The following is a description of a gene set: The chemical reactions and pathways involving glycoproteins, a protein that contains covalently bound glycose (i.e. monosaccharide) residues; the glycose occurs most commonly as oligosaccharide or fairly small polysaccharide but occasionally as monosaccharide. studied in species Mus musculus Mouse Gene Set: GOBP_GLYCOPROTEIN_METABOLIC_PROCESS, and this is the list of marker genes: B3galnt2, St6galnac5 (NCBI Gene Id 99744), Chpf2, Golph3, St3gal2, Pofut2, Frey1, St3gal6, St6galnac6, Fut1, 6430550D23Rik, Mmp12, St3gal3, Porcn, Galnt9, B3gnt7, Man2a2, Dse, Ednra, Alg14, Galns, Sulf1, Ctsl, Chsy3, Galnt5, Galnt4, Vangl2, Cwh43, Large2, Il15, Cst3, Itm2a, Chst14, Mgat5, Rpn2, Gpc1, Aga, Chst11, Ctnnb1 (catenin beta 1), B4galt1, Ube2j1, Fbxo2, Itm2c, Aatf, Hs3st1, Abca7, Pgm3, Atp7a, Dhdds (NCBI Gene Id 97199), Galnt15, Lep, Pomt1, B3gnt4, Gcnt2, Psen1, Glb1, Eogt, Ust (NCBI Gene Id 338362), Pomk, St6galnac2, Rpn1, B3galt6, Fbxo27, Ccr7, St6galnac1, Chsy1, Bmp2, Prkcsh (NCBI Gene Id 19089), Tmem258, Serpina1a, Gorasp1, Dpagt1, Man2a1, Poglut3, C1galt1c1, Galnt11, Fbxo6, Xxylt1, Pomgnt2, Ago2, Glce, Fut2, Alg8, Dpm2 (dolichyl-phosphate mannosyltransferase subunit 2, regulatory), Galntl6, Edem3, Mgat4b, Bmpr1b, Hpse, Hs2st1, Abo, St3gal4, B3galt4, Hs6st1 (heparan sulfate 6-O-sulfotransferase 1), Tmem106a, Hs3st2, Adamts12, Gcnt3, Alg5, Hbegf, B3gnt5, Chp1, Adamts7, Ids, Fam20b, Slc35b2, Mgat4f, Alg6, Man1a2, Neu2, Acot8, Man1b1, Mgat4e, Chst12 (NCBI Gene Id 59031), Plcb1 (NCBI Gene Id 98861), B3galt5 (UDP-Gal:betaGlcNAc beta 1,3-galactosyltransferase, polypeptide 5), Tmtc2, Slc35d1, Jak3, Pomgnt1, Gfpt1, B3gnt8, C1galt1, Bpnt2, Gcnt1, 4930568D16Rik, Slc35c2 (solute carrier family 35, member C2), Cant1, Trex1, Ep300, B4galt2, Plod3, B3gat1, Gcnt4, Fkrp, Galnt14, Tmem260, Engase, Extl1, Gns, B4galt3, B3glct, Alg11, Galnt7, Dpm1, Galnt16, Arsb, Poglut1, Pofut1, Extl3, Naglu, Uggt1, Galntl5, Edn1, Gal3st2c, Krtcap2, B3galt9, Edem2, St8sia4, Ganab (NCBI Gene Id 14376), Tmtc4, Galnt3 (polypeptide N-acetylgalactosaminyltransferase 3), Serpina1b, Dolk, Ndst4, Angpt1, Rxylt1, Ext1, B4galt4, Pcsk6, B3gnt6, Large1, St6gal2, B4galt5, Hs3st4, Tmtc3, Cela1, Fbxo17, Alg10b, Necab1, Slc2a10, Galnt17, Trip11, Ncstn, A4gnt, Fut8, Gnptab, Mgat4d, Insr, Fut11, B3galt1, Idua, Bace2 (beta-site APP-cleaving enzyme 2), Mogs, Tet3, Bmpr2, B4gat1 (NCBI Gene Id 72430), Pmm1, Sec1, Hexb, B3galt2, Dad1, Galnt10, Dpy19l3, Ccl19, Hs6st3, Hif1a, Asgr2, Dolpp1, B3galnt1, Tmem165, Alg2 (ALG2 alpha-1,3/1,6-mannosyltransferase), Ednrb, Soat1, Galnt13, Abca2, Ramp1, Gusb, Tmtc1, Gxylt1 (NCBI Gene Id 382997), Mgat1, Nagpa, Galnt12, Srd5a3, Cog7, Hs3st5, Xylt2, Xylt1, Poglut2 (protein O-glucosyltransferase 2), Foxl1, Chst10, Ostc, Bcl2, Mgat3, Gal3st4, Entpd5, Gcnt7, Apcs, Dpy19l1, Phlda1, Stt3b, Csgalnact2, Nus1, Nccrp1, Neu4, Fktn, Ndst2, Slc35d2, Galnt6, Tnip1, Ccdc134, Fut4, St3gal1, Necab3, Cytl1, Pxylp1, Ptx3, Slc4a10, Slc10a7, Lmf1, Tusc3, Galnt2 (NCBI Gene Id 14424), Tet1, Tmem59, Chst8, Gmppa, Csgalnact1, Tcf7l2, Oga, St6gal1, St8sia3, Stt3a, Fut10, Man1c1, Chst9, Tm9sf2, Pate6, Man1a, Gbgt1, Hyal1, Il33, Hgsnat, Hs3st3a1, Slc51b, B4galnt4, Btk, Igf1, Cog3, B4galnt3, Alg12, Magt1, Crppa, St8sia2, Mgat4c, Fut7, Ces2a, Ppard, Galnt18, Ggta1, Tet2, Gata1, B3gat3, Mgat4a, St6galnac4, Pawr, Col2a1, Ndst1, Lipc, Acer2, B4galt7, Slc39a8, B3gat2, Golga2, Hs6st2, Acan, St6galnac3, Npc1 (NCBI Gene Id 98121), Edem1, Chst3, Erp44, Ext2, Gfpt2, Ccl21a, Ganc, Chpf, St8sia5, Fut9, Fbxo44, B4galnt2, B3gnt2, Manba, Necab2, Pmm2, Uggt2, Ngly1, Mustn1, Mfsd8, Park7, Ddost, Itm2b, Mlec, Alg13, Derl3, St8sia1, B3gnt3, Rab1a, Mgat5b, Mgat2 (NCBI Gene Id 217665), B4galt6, Ogt, Galnt1, Ndst3, Hyal4, Chst1, Hs3st3b1, St8sia6, Dpm3, Arfgef1, Col11a1, Alg3 (ALG3 alpha-1,3- mannosyltransferase), Chst13, Rab1b, Alg9, Chst7, Atp4b, Sgsh, B3gnt9, Dsel, St3gal5, Vegfb, Sulf2, Gmppb, Ost4, Alg1, Rft1, Hs3st6, Trak2, Gxylt2, Ihh, Gal3st2, Aqp11, Hexa, Chst5, Ugdh, Pomt2